The following is a description of a gene set: species: Mus musculus Mouse Gene Set: GOBP_REGULATION_OF_MEMBRANE_REPOLARIZATION_DURING_ACTION_POTENTIAL Any process that modulates the rate, frequency or extent of membrane repolarization during an action potential. Membrane repolarization is the process in which membrane potential changes in the repolarizing direction, towards the resting potential., and this is the list of marker genes: Cav1, Rnf207, Kcne3, Cacnb3, Flna, Cacna2d1